Given this list of marker genes Tmem126a, Cox18, Moap1, Tomm22, Oxa1l, Bax, Bcs1l, Maip1, Tomm40, here is a description of the gene set: The process that results in the incorporation of a protein into a mitochondrial membrane. Mouse Gene Set: GOBP_PROTEIN_INSERTION_INTO_MITOCHONDRIAL_MEMBRANE species: Mus musculus